The following is a description of a gene set: Mouse Gene Set: GOBP_PROTEIN_TRIMERIZATION species: Mus musculus The formation of a protein trimer, a macromolecular structure consisting of three noncovalently associated identical or nonidentical subunits., and this is the list of marker genes: Pxdn, Scara5, Pnpt1, Clybl, Mif, Mbl1, Alox5ap, P2rx3, H2-M3 (NCBI Gene Id 14991), App, Cd74, Steap4, Ski, Sigmar1, Col1a2, Mlkl, P2rx7, Itln1, Slc1a2, Slc1a5